The following is a description of a gene set: Human Gene Set: GOCC_DENDRITE_MEMBRANE studied in species Homo sapiens The portion of the plasma membrane surrounding a dendrite., and this is the list of marker genes: KCNC3, CLCN2, HCN1, THY1, ATP2B2, GABRE, GABRA6, GABRA4, ATP6AP2, KCNC2, GABRA3, HPCA, DAGLA, GRIA1, SLC9A5, SLC12A5, GABRA5, GABRG3, LAMP5, TRPV1, GABRG2, HCN2, CACNG8, OPRD1, ATF4, KCNC4, MPP2, SHISA8, ITGA8, DDN, SHISA7, GABRA1, APP (amyloid beta precursor protein), INSR, SGCE, SHISA9, KCNB1, TACR3, PPP1R9B, KCNC1, AKAP5, GABRA2, GPER1, SHISA6, GABRG1